Given this list of marker genes BRF1, MARS2, TSEN54, TUBB3, MDH1, SHH, AMPD2, DEPDC5, EXOSC3, TSEN34, PI4KA, CCDC88C, TSEN2, APC2, WNT1, LAMA2, DISP1, POMT2, FA2H, CLCN3, B3GALNT2, EXOSC9, ARHGEF2, AGTPBP1, ROBO1, CEP290, ARL3, GLI2, SETX, EXOSC1, POMK, SETD2, ENSG00000288330, MACF1, SEPSECS, CRIPTO, SLC5A6, SNX14, UBE2A, LAMA1, RORA, TOE1, INTS11, ATXN2 (NCBI Gene Id 8095), DPM1, TMEM216, LARGE1, IDH1, VPS4A, VRK1, CSPP1, TRAPPC12, NODAL, SACS, GPHN, ZIC1, INPP5E (NCBI Gene Id 56623), FGF8, CASK, DCC, PPIL1, TUBB2B, EIF4A2, STUB1, ADGRG1, AHI1, ALG3, RELN, TSEN15, MED23, ASNS, TGIF1, CLTC, RERE, PTEN, SMARCA2, EPG5 (NCBI Gene Id 654033), RTTN, GMPPB (GDP-mannose pyrophosphorylase B), PIGA, FLI1, PI4K2A, DOCK7, DLL1, AHCY, FKRP, PTCH1, PIGS, ZIC2, SLC25A46, SIX3, PPP2R1A, GAS1, GALC, DAG1, CDON, FOXH1, KIAA0586, TUBA1A, EXOSC8, VPS51, ATXN8OS, POMGNT1, PRDM13, PMM2, POMT1, POGZ, TBC1D23, PLK4, PCLO, NPHP1, FTH1, MINPP1, TMEM67, STIL, MAB21L1, ROBO3, here is a description of the gene set: Human Gene Set: HP_ABNORMAL_PONS_MORPHOLOGY species: Homo sapiens A structural abnormality of the pons. Abnormal pons morphology